Given this list of marker genes B4GALT6, MYRF (myelin regulatory factor), CNTN2, NCSTN, B4GALT5, PLP1, CLU, FA2H, ERCC2, ID4, MIR26A1, SOX10, NKX6-2, CNTNAP1, MIOS, KCNJ10, PTEN, HES5, CCDC39, GPM6B, MAG, MAL, ABCA2, CNTN1 (contactin 1), TENM4, here is a description of the gene set: Human Gene Set: GOBP_AXON_ENSHEATHMENT_IN_CENTRAL_NERVOUS_SYSTEM The process in which a glial cell membrane closes around an axon in the central nervous system. This can be a myelinating or a non-myelinating neuron-glial interaction. studied in species Homo sapiens